The following is a description of a gene set: A protein complex that acts as a chaperone or scaffold for centriolar proteins during the maturation of the procentriole. Some of its members may become integrated into the growing centriole. Examples are the CPAP(CENPJ)-STIL complex, CEP192-PLK4 complex or CEP152-PLK4 complex in vertebrates. Human Gene Set: GOCC_PROCENTRIOLE_REPLICATION_COMPLEX species: Homo sapiens, and this is the list of marker genes: PLK4, CEP192, CENPJ (centromere protein J), SASS6, STIL, CEP152